The following is a description of a gene set: The process in which a relatively unspecialized cell acquires specialized features of a keratinocyte. Mouse Gene Set: GOBP_KERATINOCYTE_DIFFERENTIATION studied in species Mus musculus, and this is the list of marker genes: Ovol2, Mafb, Extl3, Nfkbiz, Tgm3, Krt5, Ivl, Csta1, Nme2, Stfa2, Krt77, Gak, Pkp1, Wnt5a, Smarca4, Krt74, Ugcg, Krt79, Ift74, Loricrin, Krt2, Krt73, Cstdc5, Wnt16, Lce1g, Krt83, Kazn, Epha2, Il17a, Sprr2i, Bcl11b, Ppp3ca, Krt78, Krt17, Krt4, Cstdc6, Errfi1, Krt82, Evpl, Bcr, Alox8, Pou2f3, Sprr4, Hrnr, Dsp, Krt81, Scel, Sprr2f, Srsf6, Ptgs1, Flnb, Ppl, Krt75, Csta2, Krt80 (keratin 80), Stk4, Krt71, St14, Krt16, Krtap6-5, Madcam1, Tfap2a, Krt90, Palld, Cers3, Cyp26b1, Sprr2k, Grhl1, Sprr1b, Pax6, Sav1, Rock2, Ncoa3, Gm5414, Sprr2e, Tmem79, Grhl2, Stfa2l1, Krt84, Notch1, Reg3g (NCBI Gene Id 19695), Fosl2, Il1a, Krt7, Slc39a2, Sprr2g, Krt1, Msx2, Plec, Csta3, Macroh2a2, Lce1a2, Intu, Sprr2d, Sharpin, Ubn1, Cdh3, Cyp27b1, Casp3, Krt14, Krt6b, Reg3a, Opn3, Foxn1, Krt87, Krt85, Pphln1, Lats1, Zfp36l1, Ptgs2, Gm5478, Lats2, Stfa3, Ezh2 (enhancer of zeste 2 polycomb repressive complex 2 subunit), Krt6a, Pou3f1, Txnip, Gprc5d, Cdkn2a, Clic4, Tsg101 (NCBI Gene Id 22088), Abca12, Irf6, Sprr1a, Cstdc3, Dnase1l2, Kdf1, Pnpla1, Hoxa7, Numa1, Foxc1, Dsg4 (desmoglein 4), Prkch, Cstdc4, Exph5, Macroh2a1, Stfa1, Cdsn, Zfp36, Rock1 (Rho-associated coiled-coil containing protein kinase 1, NCBI Gene Id 68785), Etv4, Tgm1 (NCBI Gene Id 69510), Psap, Krt76, Cdkn1a, Cnfn (cornifelin), Tfap2c, Trp63, Med1, Yap1, Sgpp1, Sprr2h, Krt36, Sfn, Acer1, Rbpj, Map2k1, Anxa1, Tgfb2, Vdr, Sprr2b, Sprr3, Krt10, Cd109, Krt86, Asah1, Krt72